The following is a description of a gene set: Stops, prevents or reduces the activity of any enzyme that catalyzes the hydrolysis of GTP to GDP and orthophosphate. Mouse Gene Set: GOMF_GTPASE_INHIBITOR_ACTIVITY studied in species Mus musculus, and this is the list of marker genes: Rtkn, Pde6d, Slit2, Dgki, Cpeb2